The following is a description of a gene set: Human Gene Set: GSE28726_NAIVE_CD4_TCELL_VS_NAIVE_NKTCELL_DN species: Homo sapiens from publication Constantinides MG, Picard D, Savage AK, Bendelac A (PMID 21632718) Microarray analysis was performed to determine the transcriptional profiles of NKT, CD1d-aGC+ Va24-, and CD4 T cells. Genes down-regulated in naïve T cells: CD4 versus NK., and this is the list of marker genes: GAMT, CD300C, FCER2, SIRPA, IRF2BP1, MXRA8, ARHGEF11, AMT (NCBI Gene Id 275), ANXA10, ZFP36L2, SIGLEC6, FGFR1, ARHGAP45 (Rho GTPase activating protein 45), PLCD1, RGS9, MTSS1, MAPK11, CXCR6, CDC25B (cell division cycle 25B), AQP5, DGKA, DRD4, B3GALT4, FAM3A, SMAGP, HSD3B2, PER1, GCA, RECQL5, CTSK, ITGA6, GYPB, ADRB2, UBE2C, PLIN1, ITGB2, FCHO1, CBX4, S100A13, ASL, USP19, SETD1B, SERPINF1 (NCBI Gene Id 5176), SORBS3, CASQ2 (NCBI Gene Id 845), ESR2, AFDN, BTBD2, LGALS3BP, INS, CA11, CDX2, ICAM3, ALDH2, GPSM3, RBM38, SIPA1, CORO1A, CDH22, AXIN1, ZFPL1, IFITM3, HGFAC, GATA4, OPTN, TRIB2, FADS3, KRT20, NUMA1, NCAPD2, SDC3, PIAS3, CTSA, CYFIP2, FGFR3, MYO9B, MAGEB4, CADPS, TREX1, LIPC, OCRL, RAB31, ULK2, TXNIP, PPP2R5D, PRKACG, LFNG, PTK2B, ACP5, P2RX5, IFITM1, MFGE8, TBX1, PTX3, LITAF, DISC1, AQP2, MCL1, PROZ, HDAC6, XDH, S1PR4, FCGR2B, ESR1, ATG13, KCNJ12, DNAJB1, PPARD, CHI3L2 (NCBI Gene Id 9155), RHBDL1, EN2, H4C2, RASGRP2, IZUMO4, SLCO3A1, MAP4K2, CPB1, ADD3, SLC25A42, PSD, KRT34, ITGA2B, MEGF6, PHLDA2, PCDH7, AIF1, ARID4B, UTRN, TLR1, HEXIM1, GDPD5, ID1, EYA2, CLDN9, NCKIPSD, SLC2A3, MAPRE3, TTR, TCAP, CXCR4, PAPSS2, CCDC69, PFKL, PLCG2, CXCL12, CYP3A5, PNOC, CYTH1, FCGRT, TLE5, CFP, KCNA5, CTNNBIP1, GAB2, GADD45A, NINL (NCBI Gene Id 80250), ARHGEF18, SMR3B, CDC14A, MYL2, TYR, CTSH, PHKG2, ITIH4, MCF2L, FOXO4, PIK3IP1, PXDC1, DGCR2 (NCBI Gene Id 9993), PADI2, PCNX1, ACVR2B, TRAF3IP2, BIN1, DDIT3, JUND, IL11RA, SERPINB7, MATN2, KDM2A, CDC14B, HHEX, HMGN2, JUNB, AREG, SIT1, PRRX1, CDH3, HMGB2, ASIC3, ACR, FLOT2, MAPK3, GUCY2F (NCBI Gene Id 2986), HOXA5, TOB1, SEC31B, CDC42BPA, MRNIP (NCBI Gene Id 51149), ZKSCAN5